The following is a description of a gene set: species: Mus musculus Mouse Gene Set: GOBP_SNRNA_3_END_PROCESSING Any process involved in forming the mature 3' end of an snRNA molecule., and this is the list of marker genes: Exosc8, Ints14 (integrator complex subunit 14), Ints6l, Ints5 (NCBI Gene Id 76328, integrator complex subunit 5), Ints2, Exosc7, Ints12, Ints1, Exosc2, Exosc5, Ints6, Exosc3 (exosome component 3), Ints9, Tut1, Ints8, Exosc9, Exosc6, Exosc4, Ints7, Usb1, Toe1 (target of EGR1, member 1 (nuclear))